Given this list of marker genes DSG1, GNAQ, NRAS, MARS2, GH1, OTX2, TMEM67, MAP2K1, BRAF, PROP1, CREBBP, RNU4-2 (RNA, U4 small nuclear 2), ROBO1, KMT2D, RAP1B, KDM6A, PNPLA6, DNA2, POU1F1, MPV17, FANCI, MANF, here is a description of the gene set: species: Homo sapiens Reduced circulating growth hormone concentration Human Gene Set: HP_REDUCED_CIRCULATING_GROWTH_HORMONE_CONCENTRATION Concentration of growth hormone in the blood circulation below normal limits.